The following is a description of a gene set: Mouse Gene Set: LEE_CALORIE_RESTRICTION_MUSCLE_UP from publication Lee CK, Klopp RG, Weindruch R, Prolla TA (PMID 10464095) species: Mus musculus Up-regulated in the gastrocnemius muscle of aged (30-month) mice subjected to caloric restriction diet since young adulthood. The gene expression profile of the aging process was analyzed in skeletal muscle of mice. Use of high-density oligonucleotide arrays representing genes revealed that aging resulted in a differential gene expression pattern indicative of a marked stress response and lower expression of metabolic and biosynthetic genes. Most alterations were either completely or partially prevented by caloric restriction, the only intervention known to retard aging in mammals. Transcriptional patterns of calorie-restricted animals suggest that caloric restriction retards the aging process by causing a metabolic shift toward increased protein turnover and decreased macromolecular damage., and this is the list of marker genes: Cltb, Actb, Ppard, Gip, Atp1a2, Mybph, Gpd1, Adipoq, Psmb7, Aldoc, Cyp2c40, Pparg, Fbp2, Psme1, Slc1a5, Ppp1r2, Npy4r, Ndn, Ctnna1, Fasn (NCBI Gene Id 353049), Glul, Pex5, Actc1, Eef1g, Cryge, Pnp, Fzd6, Prkcsh, Lta, Car4, Psmc3, Myh7 (NCBI Gene Id 17889), Thbd, Cmpk2, Fabp5, Ssr4, Ddit3, Guca1a, Plin2, Tkt